Given this list of marker genes Catsper3, Izumo4, Dmc1 (DNA meiotic recombinase 1), Zp1, Adam2, Adam30, Hyal5, Zp3, Adam25, Firrm, Izumo2, Zp2, Cd9, Acr, Fignl1, Hvcn1, Kcnu1, Izumo1 (NCBI Gene Id 73456), Adam21, Catsperb, Catsperg1, Catsper1, Catsper4, Izumo3, here is a description of the gene set: electronically inferred by orthology from the curated human pathway This event has been computationally inferred from an event that has been demonstrated in another species.<p>The inference is based on the homology mapping from PANTHER. Briefly, reactions for which all involved PhysicalEntities (in input, output and catalyst) have a mapped orthologue/paralogue (for complexes at least 75% of components must have a mapping) are inferred to the other species. Reactome Pathway: Reproduction species: Mus musculus